Given this list of marker genes CA2, SIRT2, PPP1R14A, APOD, SLC44A1, CLDN11, HSPA2, PLP1, MAL, KLK6, FAM107B, GSN, MAG, MBP, PTGDS, QDPR, SELENOP, TUBB4A, STMN4, SLC48A1, S100A1, APLP1, SCD, BIN1, TMEM144, CRYAB, TF, SPOCK3, CLDND1, PLEKHB1, ELOVL1, PLAAT3, UGT8, CMTM5, PLLP, ATP1B1, RNASE1, CNP, SLAIN1, ANKS1B, PACS2, HAPLN2, LHPP, ANLN, ABCA2, LARP6, MOBP, ERMN, here is a description of the gene set: In this study, an extensive analysis was conducted to define meta-programs (MPs) capturing intra-tumor heterogeneity across a spectrum of tumor types. The approach utilized non-negative matrix factorization (NMF) to analyze each cell type separately within individual tumor samples. This involved the analysis of malignant cells, macrophages, fibroblasts, endothelial cells, epithelial cells, T-cells, and B-cells. NMF was executed with varying parameter values (K=4, 5, 6, 7, 8, 9), thereby generating 39 programs for each cell type per sample. Each NMF program was summarized by the top genes based on NMF coefficients.\nRobust MPs were then delineated for each cell type using a set of stringent criteria, including recurrence within the same tumor, similarity to programs in other tumors, and non-redundancy within a tumor. Subsequently, these robust NMF programs were clustered (per cell type) based on Jaccard similarity, leading to the identification of MPs associated with each cell type.\nTo enhance the quality of the MPs, a refinement steps were undertaken, involving the removal of MPs suspected of reflecting low-quality data (with an overrepresentation of ribosomal proteins or mitochondrial-encoded genes), single-study inclusion, or similarity to miss-annotated cell types. Human Gene Set: GAVISH_3CA_MALIGNANT_METAPROGRAM_28_OLIGO_NORMAL from publication Gavish A, Tyler M, Greenwald AC, Hoefflin R, Simkin D, Tschernichovsky R, Galili Darnell N, Somech E, Barbolin C, Antman T, Kovarsky D, Barrett T, Gonzalez Castro LN, Halder D, Chanoch-Myers R, Laffy J, Mints M, Wider A, Tal R, Spitzer A, Hara T, Raitses-Gurevich M, Stossel C, Golan T, Tirosh A, Suvà ML, Puram SV, Tirosh I (PMID 37258682) species: Homo sapiens Genes upregulated in subsets of cells of a given type within various tumors